Given this list of marker genes P4htm, Hoxa7, Psg21, H2-T23, Hbegf, Slc20a1, Hoxa10, Apol9a, Cmbl, Rnf138, Car5b, Dynlt3, Tnrc6a, Cpsf6, Myocd, Nr3c1, Slco1a6, Nap1l3, St3gal6, Mapre2, C030010L15Rik, Pfkfb2, Cryl1, Olig2, Trim44, Trp53, Galns, Plgrkt, Emp2, Smoc2, Tnfaip8, Qng1, Sbspon, Rpgr, Gk, Rmdn1, Spdya, Ccl7, Jam2, Atp7a, Mark1, Dtna, Wdr37, Cryaa, Lysmd2, Tpgs2, Ank3, S1pr3, Id2, Gjb2, Pdk1, Ankrd50, Csgalnact1, Arsj, Ccl2, Adal, Lhx9, Rp2, Matr3, En1, Emc9, Sbno2, Huwe1, Manba, Prtg, Cnrip1, Lyn (LYN proto-oncogene, Src family tyrosine kinase), Strbp, Zfp422, Pitx2, Camk1d, Cxcl12, Nr2c2, Thoc1, Igfbp7, Akr1b8, Rbmx, Tubb2b, Enpp5, Zmym2, Zfp454, Wac, Rpl15, Zfp467, Tsr2, Ccdc103, Wdr33 (WD repeat domain 33), C2cd3, Disp1, Gas2l3, Fjx1, Snhg14, Mbtps2, Tcaf1 (NCBI Gene Id 77574), Plxna2, Slbp, Zfp518a, Gata6, Prpf3 (pre-mRNA processing factor 3, NCBI Gene Id 70767), 1700113H08Rik, Nrp1, Ifi211, Mau2, Ankrd29, Rnf130, Glb1l, Myo5a, Gprin3, Mnd1, 2310001H17Rik, Gsdme (gasdermin E), Ankrd28, Nav3 (NCBI Gene Id 676640), Myh9, Ifi205, Zdhhc20, Tnfaip2, Btbd7, Brd8, Arhgap32, Ttc9, Usp14, Wasl, Apc, Cfap91, Adgrl4, Slc43a3, Maoa, C1ql3, Htra1, Zfp286, Trim2, Ssx2ip, Kdm5c, Cct3, Eid2, Tgm2, Pcdh19, Thbs2, Ap1s3, Kat7, Nid1, Vegfd, Kif24, Cenpe, Jmjd1c, Yes1, Nipal1, Gda, Gla, Ythdc2, Syap1, Dnaja4, Sh3kbp1, P3h2, Hdac2, Pacc1, Aco1, Erich3, Zfp60, Trim9, Chd8, ENSMUSG00000134326, Prelid2, Got2, Gnpda2, Pak5, Egr1, Rif1, Setd5, Pitrm1, Srrm2, Wls, Akap17b, Fhdc1, Ncam1, Scrg1, Sord, Steap2, Pde8a, Rtp4, Plpp3, B3gat1, C3ar1, Tdrkh, Lig3, Arrdc3, Syt12, Kmt5a, Gmds, Atp6v1b2, Wipf1, Ppm1h, Rgs2, Clstn1, Flt1, Mospd2, Pcsk6, Dtl, Cd209b, Ccn1, Ebf1, here is a description of the gene set: species: Mus musculus The reciprocal chromosomal translocation t(4;11) is correlated with infant, childhood, adult and therapy-related high-risk acute leukemia. Here, we investigated the biological effects of MLL.AF4, AF4.MLL or the combination of both reciprocal fusion proteins in a conditional in vitro cell culture model system. Several parameters like cell growth, cell cycling capacity, apoptotic behavior and growth transformation were investigated under physiological and stress conditions. Co-transfected cells displayed the highest resistance against apoptotic triggers, cell cycling capacity and loss-of-contact inhibition. These analyses were complemented by gene expression profiling experiments and specific gene signatures were established for each of the three cell lines. Interestingly, co-transfected cells strongly upregulate the homeobox gene Nanog. In combination with Oct4, the Nanog homeoprotein is steering maintenance of pluripotency and self-renewal in embryonic stem cells. Transcription of Nanog and other stem cell factors, like Oct4 and Bmi1, was verified in biopsy material of t(4;11) patient cells which express both reciprocal t(4;11) fusion genes. In conclusion, the presence of both reciprocal MLL fusion proteins confers biological properties known from t(4;11) leukemia, suggesting that each of the two fusion proteins contribute specific properties and, in combination, also synergistic effects to the leukemic phenotype. from publication Gaussmann A, Wenger T, Eberle I, Bursen A, Bracharz S, Herr I, Dingermann T, Marschalek R (PMID 17130830) Up-regulated genes from the set A (Fig. 5a): specific to cells expressing MLL-AF4 fusion protein alone. Mouse Gene Set: GAUSSMANN_MLL_AF4_FUSION_TARGETS_A_UP